The following is a description of a gene set: A human mitochondrion contains about 1500 proteins, more than 99% of which are encoded in the nucleus, synthesized in the cytosol and imported into the mitochondrion. Proteins are targeted to four locations (outer membrane, intermembrane space, inner membrane, and matrix) and must be sorted accordingly. Newly synthesized proteins are transported from the cytosol across the outer membrane by the TOMM40:TOMM70 complex. Proteins that contain presequences first interact with the TOMM20 subunit of the complex while proteins that contain internal targeting elements first interact with the TOMM70 subunit. After initial interaction the protein is conducted across the outer membrane by TOMM40 subunits. In yeast some proteins such as Aco1, Atp1, Cit1, Idh1, and Atp2 have both presequences that interact with TOM20 and mature regions that interact with TOM70.<br>After passage across the outer membrane, proteins may be targeted to the outer membrane via the SAMM50 complex, to the inner membrane via the TIMM22 or TIMM23 complexes, to the matrix via the TIMM23 complex, or proteins may fold and remain in the intermembrane space. Presequences on matrix and inner membrane proteins cause interaction with TIMM23 complexes; internal targeting sequences cause outer membrane proteins to interact with the SAMM50 complex and inner membrane proteins to interact with the TIMM22 complex. While in the intermembrane space hydrophobic proteins are chaperoned by the TIMM8:TIMM13 complex and/or the TIMM9:TIMM10:FXC1 complex. Reactome Pathway: Mitochondrial protein import species: Homo sapiens part of: Protein localization, and this is the list of marker genes: CMC4, COX19, ATP5F1A, TOMM6, SLC25A12, MTX2, SLC25A6, TAFAZZIN, HSCB, COX17, GRPEL1, HSPA9, TOMM70, SLC25A4, NDUFB8, ATP5F1B, CHCHD5, CYC1, COA4, TIMM17A, TIMM8A, SAMM50, TIMM10, FXN, CHCHD3, OTC, TIMM21, IDH3G, HSPD1, PMPCA, CHCHD7, PMPCB, TIMM8B, TIMM10B, TOMM5, CHCHD2, SLC25A13, ACO2, CS, VDAC1 (voltage dependent anion channel 1), PITRM1, TIMM23 (translocase of inner mitochondrial membrane 23), COQ2, MTX1, LDHD, GFER, ATP5MC1, TIMM44, BCS1L, CHCHD4, TIMM9, TIMM17B, PAM16, TIMM22, CMC2, TIMM50, TOMM7, TOMM22, GRPEL2, DNAJC19, TOMM20, COA6, CHCHD10, TOMM40, TIMM13